Given this list of marker genes Nprl3, Wdr59, Castor2, Sesn1, Castor1, Wdr24, Depdc5, Nprl2, Sec13, Rraga, Sesn2, Szt2, Sesn3, Seh1l, Mios, here is a description of the gene set: species: Mus musculus A GTPase-activating protein (GAP) complex that regulates TORC1 signaling by interacting with the Rag GTPase. In S. cerevisiae the complex contains Seh1p, Sec13p, Npr2p, Npr3p, Iml1p, Mtc5p, Rtc1p, and Sea4p. Mouse Gene Set: GOCC_SEH1_ASSOCIATED_COMPLEX